The following is a description of a gene set: Genes positively differentially expressed in cell type: MigDC (migratory dendritic cell) upon treatment with cytokine: TNF-α in mouse lymph nodes in vivo. from publication Cui A, Huang T, Li S, Ma A, Pérez JL, Sander C, Keskin DB, Wu CJ, Fraenkel E, Hacohen N (PMID 38057668) studied in species Mus musculus Mouse Gene Set: CUI_MIGDC_TNFA_RESPONSE_UP Cytokines mediate cell-cell communication in the immune system and represent important therapeutic targets. A myriad of studies have highlighted their central role in immune function, yet we lack a global view of the cellular responses of each immune cell type to each cytokine. To address this gap, the authors created the Immune Dictionary, a compendium of single-cell transcriptomic profiles of more than 17 immune cell types in response to each of 86 cytokines (>1,400 cytokine-cell type combinations) in mouse lymph nodes in vivo. A cytokine-centric view of the dictionary revealed that most cytokines induce highly cell-type-specific responses. For example, the inflammatory cytokine interleukin-1β induces distinct gene programmes in almost every cell type. A cell-type-centric view of the dictionary identified more than 66 cytokine-driven cellular polarization states across immune cell types, including previously uncharacterized states such as an interleukin-18-induced polyfunctional natural killer cell state., and this is the list of marker genes: Il4i1, Ndrg1, Vwa5a, P2ry10, Cfl1, Ehd1, Tmem131l (transmembrane 131 like), Pik3r1, Actr3, Cd274, Tspan33, Irf1, Ikzf4, Ccl22, Actn1, Ly75, Sema4a, Sumo2, Filip1l, Calcrl, Stxbp6, Dscaml1, Trim35, Rnf149, Txn1, Psd3, N4bp1, Litaf, Nfkbia, Cd82, Adprh (NCBI Gene Id 11544), Serpinb6b, Myl12a, Igsf8 (immunoglobulin superfamily, member 8), Cd86, Ube2z, Ccr7, Wnk1, Plagl2 (pleiomorphic adenoma gene-like 2), H2-T23, Itga4, Lactb, Casp4, Cd70, Iscu, Glipr2, Fscn1, Cd80, Cst3, Basp1, Ifi47, Pde4b, Fam107b, Fchsd2, Hcls1, Washc1, Slc27a3, Fnbp1, Tcf4, Dock10, Lcp1, Tmbim6, Pvr, Ube2l6, Cd40, Tagln2, Clic4, Ptpn1, Serpinb9, Rab8b, S100a11, Crtc2 (CREB regulated transcription coactivator 2), Gpr183, Traf6, Plscr1, Tbc1d8, Cmip, Tnfaip3, Lgmn, Csf1, Ebi3, Mkrn1, Tspo, Jag1, Nup62, Vcp, Ccdc71l (coiled-coil domain containing 71 like), Calm1, Rapgef6, Icam1, Niban1 (NCBI Gene Id 98556), Itm2c, Nfkbib, Ccl17, Idi1, Cytip, Rin3, Npr1, Plcl2, Slfn5, Tspan13, Samsn1, Foxp4, Fam53b, Htra2, Cyth1, Rasa2, Cd81, Nrros, Srgn, Cd302, Ifitm2, Flnb, Marcksl1, Snn, Col27a1, Sp110, Rbms1, Etv6, Atp11a, Pxn, Nfkb2, Fas, Cd200, Pik3r5, Bcl2l1, Cdc42ep3, Gramd2b, Selplg, Atp6v0a1, Ccnd1, Bcl2l11, Bcl7c, Psma6, Igsf9, Anxa2, Akap9, Orai1, Sel1l, Prnp, Ndufv2